The following is a description of a gene set: Mouse Gene Set: ZFP872_TARGET_GENES from publication Yevshin I, Sharipov R, Kolmykov S, Kondrakhin Y, Kolpakov F (PMID 30445619) studied in species Mus musculus, and this is the list of marker genes: Rigi, Cops7b, Gm8883, Gm6736, Pisd-ps1, Cacnb2, Ess2, Gm9496, Rps12-ps7 (NCBI Gene Id 670421), Nfkbid, Zfr, Gas2, Fam117a (NCBI Gene Id 215512), Cp (ceruloplasmin), Gm14222, Exosc2, Rell1 (NCBI Gene Id 212629), Kit, Toe1, Mir7656, Gm24965, Atp5f1d (NCBI Gene Id 97661), Itpr2, Gm23382, Adamts19, Krtap20-2, Rcor2, Jsrp1, Myom2, Gm20005, Atrip, 4930526A20Rik, Shmt1, Ltbp3, Cyp4a28-ps, Gm12333, 1700022A21Rik, Psmd2, Tns3, Mir6405